Given this list of marker genes BEX4, EP300, PRKAA1 (NCBI Gene Id 5562), FRY, FLNA, MAPT, PRKAA2, HDAC6, SIRT2, TPPP, here is a description of the gene set: The removal of an acetyl group from tubulin. An acetyl group is CH3CO-, derived from acetic acid. studied in species Homo sapiens Human Gene Set: GOBP_TUBULIN_DEACETYLATION